The following is a description of a gene set: The chemical reactions and pathways involving sphingolipids, any of a class of lipids containing the long-chain amine diol sphingosine or a closely related base (a sphingoid). Mouse Gene Set: GOBP_SPHINGOLIPID_METABOLIC_PROCESS species: Mus musculus, and this is the list of marker genes: Vapa, St6galnac1, Smpdl3b, Alox12b, St8sia3, Abca12, Cers2, Asah2, B4galt5, Gla, Lct, Psap, Pnpla1, B3galt1, Cel (NCBI Gene Id 78484), Agk, Cers3, Gal3st1, Cers5, Hacd1, B4galt4, Psapl1, Cers6, Sptlc2, Abca8a, St6galnac6, Gm2a, Smpd2, Degs1, St3gal3, Hacd3, Kdsr, 6430550D23Rik, Degs2, Elovl1, B4galnt1, Asah1, Th, Sphk1, Bax, St6galnac5, Crem, Plpp3, Smpd4, St8sia6, Fa2h, Gba2, Gzmb, Cerk, Kit, Gm6993, A4galt, Pemt, Sgpp1, Smpdl3a, Sgpl1, Cln8, Zfp750, Gsdmd, Tecr, Acer3, Acer2, Sgms1, Enpp7, Mecr, B3gnt5, Fut4 (fucosyltransferase 4), Hexa, Prkcd, Prf1, Etnppl, Neu1, Atg7, Aloxe3, Ugt8a, Elovl5, Spns2, St8sia4, Plpp2, Elovl7, Tlcd3b, Pla2g15, Fut9, Degs1l (NCBI Gene Id 619326), Galc, Hacd2, St8sia1, St3gal2, Smpd5, Sftpb, Cln6, Itgb8, Sptlc1, Gba1, Glb1, St8sia2, Abca8b, Arv1, Samd8, Map7, Fads3, Acer1 (alkaline ceramidase 1), Smpd3 (NCBI Gene Id 80691), Casp1, Plpp1, Vps54, Tm9sf2, A3galt2, P2rx7, St3gal1, B3galt4, Ormdl2, P2rx1 (NCBI Gene Id 18568), St6galnac3, B4galt6, Elovl3, Elovl4, Htra2, Cers4, Neu4, Ormdl1, Ccn1, Naglu, Neu3, Smpd1, B4galt3, Sptssa, Serinc1, Cers1, Cyp4f39, St8sia5, Enpp2, Neu2, Sptlc3, Pla2g6, Abca2, Casp7, Sptssb, Gbgt1, Fut7, Hexb, B3galt2, Sgms2, Osbp, Zpbp2, Sphk2, Cert1, Ugcg (NCBI Gene Id 97164), Sgpp2, Ormdl3, Elovl2, Sirt3, Paqr4, St6galnac4, Hacd4, Cerkl, Elovl6, Naaa